Given this list of marker genes TARDBP, COA8, PPARGC1A, ANG, MT-CO1, CFAP410, FIG4, FUS, TREM2, CCNF, OBSCN, VCP, NEFH, ERBB4, UNC13A, DAO, PRPH, DKK1, MTM1, CHCHD10, GLE1, OPTN, HNRNPA1, GLT8D1, TBK1, ANXA11, PON1, PON3, LPIN1, PON2, SOD1, MATR3, MT-CO3, ATXN2, CHMP2B, UBQLN2, VAPB, SQSTM1, PFN1, DCTN1, TAF15, NEK1, here is a description of the gene set: Fatigable weakness of swallowing muscles studied in species Homo sapiens Human Gene Set: HP_FATIGABLE_WEAKNESS_OF_SWALLOWING_MUSCLES A type of weakness of the muscles involved in swallowing that occurs after a muscle group is used and lessens if the muscle group has some rest. That is, there is diminution of strength with repetitive muscle actions.